The following is a description of a gene set: studied in species Homo sapiens from publication Chen Y, Wang X (PMID 31504780) Genes predicted to be targets of miRBase v22 microRNA hsa-miR-451b in miRDB v6.0 with MirTarget v4 prediction scores > 80 (high confidence targets). Human Gene Set: MIR451B, and this is the list of marker genes: ARL1, PRPF18, SRI, PCSK5, KIF11, CADPS, PTGER2, KIAA0232, PRKCE, ZNF106, FOXQ1, TMEM74, LMO3, CYRIB, TOX3, PRKAR2A, ZFHX3, TENT5A, DSTN, ENKUR, ADCY3, OPRPN, DHFR, ZNF805, ELAVL4, SLC37A2, ENTPD1, CILP, ABCC5, LEMD3, AEBP2, RNF168, TBC1D7, RNGTT, DAB2, ZNRF2, ANKRD62, POM121, SIAH2, MED13, KCNMB3, ADAMTS2, WAPL, FAM131B (NCBI Gene Id 9715), CCDC152, BACH2, DOCK5, FNTA, TRIM3, ALAS1, PGAP1, PPP3R1, TMEM229B, RAB10, VPS13C, PGPEP1, C9orf72, SRSF1, STK35, VAPA, ENC1, RPE, IRS2, NSMCE3, TBC1D9, RHPN2, NETO1, GCNT2 (glucosaminyl (N-acetyl) transferase 2 (I blood group)), MRTFB, PLS3, NPTX1, UXS1, CUX1, LGR4, PRUNE2, KITLG, SHC4, FBXO32, SPTSSA (serine palmitoyltransferase small subunit A), TRPS1, TVP23B, TVP23C, DCBLD2, PCYT1B, WLS, SH3GL2 (NCBI Gene Id 6456), CADPS2, MGP, SP2, PABPC1, CLCN4, BACE1, SERPINB9, GRIA3, TACC2, KREMEN1, JADE1, GABRG3, PTPRR, KCNJ10, GPATCH2L, FBLN5, ONECUT2, ZNF518A (zinc finger protein 518A), ASB4, EPG5, AQP9, MYCBP2, HERC3, AGO4, GABPB1, CHFR, ACYP2, KLRD1, ZMPSTE24, FZD7 (NCBI Gene Id 8324), FEZ2, SAMSN1, ACAP2, DHFR2, JRK, FKBP1B, EFCAB3, HECW2, AAK1, STXBP6, TDRD15, ERBIN, NELL1 (neural EGFL like 1), UNC79, YIPF3, SKIC3, FAF2, TTC33, ADAMTS18, RHOA, CASK, LSM4, JOSD1, CALB1, TESMIN, TBL1XR1, VEGFA, LRRN4CL, CUL3, M6PR (NCBI Gene Id 4074), OPRK1, PACSIN2, ARB2A, ZNF250, AGO1, SGPP2, TLK2, PROS1, SYTL4, DYNAP, ZXDC, TNFAIP8, ARHGAP18, ALS2, INSM1, DNER, KPNA3, EED, PRRT1, NEXMIF, CD207, PDE1C, SYNM